The following is a description of a gene set: studied in species Mus musculus Reactome Pathway: E3 ubiquitin ligases ubiquitinate target proteins This event has been computationally inferred from an event that has been demonstrated in another species.<p>The inference is based on the homology mapping from PANTHER. Briefly, reactions for which all involved PhysicalEntities (in input, output and catalyst) have a mapped orthologue/paralogue (for complexes at least 75% of components must have a mapping) are inferred to the other species. electronically inferred by orthology from the curated human pathway part of: Protein ubiquitination, and this is the list of marker genes: Rnf40, Ube2e1, H2bc8, Rnf152, Pex5, H2bc15, H2bc9, Pex13, Rps27a, H2bc22, Ube2n, Pex12, Leo1, H2bc1, Pcna, H2bc12, H2bc13, H2bc3, Ube2d1, Prkdc, H2bc7, Ubb, Ctr9, H2bc11, Rraga